Given this list of marker genes SLC29A2, RABGGTA, AVPR1B, DDX18, FCGR2B, TFE3, CD8B, NRF1, PMS2P11, GPR3, VPS72, CHMP1A, DPF2, CSTF3, GH2, LTK, RNPS1, PSG7, HNRNPL, TAF11, PPP2R5A, SF1, SMARCC1, PLK1, SIRPB1, TCF20, MYH7, PDE6B, ZNF134, AQP2, TMEM106A, CDH5, SLC18A1, GSTZ1, SUPT4H1, GPER1, REG1CP, PTPN5, AIP, RFX5 (regulatory factor X5), ADRB3, HIVEP1, GJA5, DGCR6, ZNF8, FEV, MICB, MPP2, MAZ, RING1, TH, ODF1, KRT6C, PEX5, COL14A1, AAMP, CENPI, SIGMAR1, GCGR, SDHC, GABRQ, KRT35, TIMM17A, FUT2, TTC1, SLC17A2, SLC16A1, SMARCD1 (NCBI Gene Id 6602), ABCC1, KRT32, VAV1, BCAT2, AQP6, MIEF1, SLC2A4, SMARCD2 (SWI/SNF related, matrix associated, actin dependent regulator of chromatin, subfamily d, member 2), MADD, MAP1A, CLCN7, PRKCG, ADCYAP1, AQP7, DRG2, TAF1, ERV3-1, CCL2, DRAP1, GRM4 (glutamate metabotropic receptor 4), BECN1, MVK, RENBP, IDUA (alpha-L-iduronidase), TRIP13, RIT1, LYST, CCR9, FCGR2A, ERCC4, MAPRE1, NDUFA1, FANCC, HMGA2, MAPK3, TTF1, PLG, NEFL, APOC3, COX10, GLA (NCBI Gene Id 2717), AANAT, IKBKE, CSN3, BNIP1, IFNA21, DRD1, TLK2, TEC, KRT83, WAS, AGER, CHIC1, NQO2, NGFR, PRKAG1, EBI3, PSD, here is a description of the gene set: Human Gene Set: GCM_FANCC studied in species Homo sapiens Neighborhood of FANCC Neighborhood of FANCC Fanconi anemia, complementation group C in the GCM expression compendium